Given this list of marker genes TLR4, TICAM2, FASLG, CFLAR, FAS (Fas cell surface death receptor), CD14, TICAM1, MC159L, TNFRSF10B, TNFRSF10A, LY96, CASP8, TRADD, TNFSF10, TRAF2, FADD, RIPK1 (receptor interacting serine/threonine kinase 1), ORF71, here is a description of the gene set: part of: Caspase activation via extrinsic apoptotic signalling pathway studied in species Homo sapiens Reactome Pathway: Caspase activation via Death Receptors in the presence of ligand Caspase-8 is synthesized as zymogen (procaspase-8) and is formed from procaspase-8 as a cleavage product. However, the cleavage itself appears not to be sufficient for the formation of an active caspase-8. Only the coordinated dimerization and cleavage of the zymogen produce efficient activation in vitro and apoptosis in cellular systems.<p>The caspase-8 zymogens are present in the cells as inactive monomers, which are recruited to the death-inducing signaling complex (DISC) by homophilic interactions with the DED domain of FADD. The monomeric zymogens undergo dimerization and the subsequent conformational changes at the receptor complex, which results in the formation of catalytically active form of procaspase-8..